The following is a description of a gene set: The specific behavior of an organism in response to a novel environment or stimulus. Mouse Gene Set: GOBP_EXPLORATION_BEHAVIOR studied in species Mus musculus, and this is the list of marker genes: Dlg4, Apoe, Atxn3, Agtr2 (angiotensin II receptor, type 2), Chrd, Ndp, Gabrb3, Lmo3, Tnr, Slc4a10, Brinp1, Gad1, Penk, Naglu, Fmr1, Dcaf11, Jph3, Vps13a, Abat, Kmt2a, Minar2, Shank3, Atp1a2, Lrrtm1, Grn, Shank2, Ube3a (ubiquitin protein ligase E3A), Gip (gastric inhibitory polypeptide), Kcnq2, Lrrk2, Lsamp, Abcb1b, Abtb3, Htr1a, Nlgn2 (NCBI Gene Id 216856), Abcc1, Chl1, Ptpn5, Crhr1, Comt, Crbn, Abl2, Myg1, Tuba1a (NCBI Gene Id 22142), Itga3, Chrna4, Crh, Slc4a7, Dpp4, Nog (noggin), Brinp3, Prkce